The following is a description of a gene set: Estrogens regulate normal ovarian surface epithelium (OSE) cell functions but also affect epithelial ovarian cancer (OCa) development. Little is known about how estrogens play such opposing roles. Transcriptional profiling using a cDNA microarray containing 2400 named genes identified genes whose expression was altered by estradiol-17beta (E2) in three immortalized normal human ovarian surface epithelial (HOSE) cell lines and genes whose expression was affected by the hormone in three established OCa (OVCA) cell lines. All but 19 of the genes in these two sets were different. Among the 19 overlapping genes, five were found to show discordant responses between HOSE and OVCA cell lines. The five genes are those that encode clone 5.1 RNA-binding protein (RNPS1), erythrocyte adducin alpha subunit (ADD1), plexin A3 (PLXNA3 or the SEX gene), nuclear protein SkiP (SKIIP), and Rap-2 (rap-2). RNPS1, ADD1, rap-2, and SKIIP were upregulated by E2 in HOSE cells but downregulated by estrogen in OVCA cells, whereas PLXNA3 showed the reverse pattern of regulation. The estrogen effects was observed within 6-18 h of treatment. In silicon analyses revealed presence of estrogen response elements in the proximal promoters of all five genes. RNPS1, ADD1, and PLXNA3 were underexpressed in OVCA cell lines compared to HOSE cell lines, while the opposite was true for rap-2 and SKIIP. Functional studies showed that RNPS1 and ADD1 exerted multiple antitumor actions in OVCA cells, while PLXNA3 only inhibited cell invasiveness. In contrast, rap-2 was found to cause significant oncogenic effects in OVCA cells, while SKIIP promotes only anchorage-independent growth. In sum, gene profiling data reveal that (1) E2 exerts different actions on HOSE cells than on OVCA cells by affecting two distinct transcriptomes with few overlapping genes and (2) among the overlapping genes, a set of putative oncogenes/tumor suppressors have been identified due to their differential responses to E2 between the two cell types. These findings may explain the paradoxical roles of estrogens in regulating normal and malignant OSE cell functions. from publication Syed V, Zhang X, Lau KM, Cheng R, Mukherjee K, Ho SM (PMID 16116479) Genes responsive to estradiol both in normal and cancer ovarian cell lines. species: Homo sapiens Human Gene Set: SYED_ESTRADIOL_RESPONSE, and this is the list of marker genes: ACHE, SNW1, PLEK, ACP1, RNPS1, SOCS2, UCP2, CLIC1, CASK, MYO5A, PARP1, KPNA2, TGM3, PLXNA3, RAP2A, PPP2R5E, CLIP1, RPL29